The following is a description of a gene set: Transcription factor Foxp3 (forkhead box P3), restricted in its expression to a specialized regulatory CD4+ T-cell subset (T(R)) with a dedicated suppressor function, controls T(R) lineage development. In humans and mice, Foxp3 deficiency results in a paucity of T(R) cells and a fatal breach in immunological tolerance, causing highly aggressive multi-organ autoimmune pathology. Here, through genome-wide analysis combining chromatin immunoprecipitation with mouse genome tiling array profiling, we identify Foxp3 binding regions for approximately genes and for an intergenically encoded microRNA. We find that a large number of Foxp3-bound genes are up- or downregulated in Foxp3+ T cells, suggesting that Foxp3 acts as both a transcriptional activator and repressor. Foxp3-mediated regulation unique to the thymus affects, among others, genes encoding nuclear factors that control gene expression and chromatin remodelling. In contrast, Foxp3 target genes shared by the thymic and peripheral T(R) cells encode primarily plasma membrane proteins, as well as cell signalling proteins. Together, our studies suggest that distinct transcriptional sub-programmes implemented by Foxp3 establish T(R) lineage during differentiation and its proliferative and functional competence in the periphery. from publication Zheng Y, Josefowicz SZ, Kas A, Chu TT, Gavin MA, Rudensky AY (PMID 17237761) Human Gene Set: ZHENG_FOXP3_TARGETS_UP species: Mus musculus Genes with promoters bound by FOXP3 and which are up-regulated both in developing (located in the thymus) and mature (from peripheral blood) regulatory CD4+ T lymphocytes., and this is the list of marker genes: CD44, CDC42SE2, SNX14, COBLL1, PRDM1, RHOH, P4HA1, IRF6, FRMD4B (NCBI Gene Id 23150), IL2RA, UBASH3B, CREM, MAP3K8, PRKCH, ICOS, LRRC8C, ABCB1, IKZF2, SNX9, IFNGR1, NRP1, EEF1AKMT1, TENT5C, ARL6, CTLA4, FAM107B